Given this list of marker genes CES2, DOCK2, CRTAP, TNS3, BCL3, TOM1, SLC3A2, C1orf162, SLC25A28, BTBD2, RIPOR1, CD33, LILRA6, NCLN, ARRDC3, ENTREP3, NACC2, GRN, CARM1, BHLHE40, CXCL16, HLA-DRB4, CSF1R, ACSS2, ZNF362, GRAMD4, SPG21, CREG1, ADAP1, JMJD8, SLC26A6, ALOX5, SRF, NINJ1, GMEB2, MILR1, CIRBP (NCBI Gene Id 1153), ZNF467, ADAP2, ALDH1A1, GAS7, PFKFB3, VSIR, CD86, IMPDH1, OAF, CNPY3 (canopy FGF signaling regulator 3), PPM1F, ANXA5, RCC2, NAPRT, C9orf72, H3-3B, GADD45B, PNPLA6, LILRA3, MAPKAPK3, RNASET2, PIM3, TYK2, CDC37, ZNF296, FUT4, MPEG1, CTNNA1, CENPB, ZDHHC7, RAPGEF1, ZNF598, SLC66A2, TNFRSF1B, CLCN7, KATNIP, TBC1D2 (NCBI Gene Id 55357), FAM156A, RFNG, LGALS9, ALDOA, ULK1, FAAP100, WWP2, DAZAP2, AP1S2, CMIP, LRP3, MACROH2A1, RHOG, SEPTIN9, HCFC1, TPD52L2 (NCBI Gene Id 7165), KDM2B, SLC9A1, DMXL2, SNX27, ADAM15, CALM3, SLC43A2, NSMF, KHSRP, C15orf39, MYOF, CHST13, ZYX, ALDH2, RAB40C, ATF5, ALAD, CDC42EP3, PLSCR1 (phospholipid scramblase 1), BCKDK, FBP1, HNRNPH2, ATP6AP1, GNAQ, TRIM8, IRF1, TGOLN2, CCNY, STK25, KLF10, KLF11, ATP6V0A1, PSAP, BICRA, CD300C, TSPO, H3-5, ZMIZ1, NIBAN2, ITGB2, PIEZO1, SHFL, NUAK2, MAP3K20, JARID2 (NCBI Gene Id 3720), SLC2A6, MYH9, RUNX3, RNPEP, ABR, CBX4, RAB44, FGR, DENND5A, NCSTN, CLEC16A, LZTR1, CUEDC1, here is a description of the gene set: species: Homo sapiens Human Gene Set: THAKAR_PBMC_INACTIVATED_INFLUENZA_AGE_70PLS_NONRESPONDER_2DY_DN To elucidate gene expression pathways underlying age-associated impairment in influenza vaccine response, we screened young (age 21-30) and older (age >= 65) adults receiving influenza vaccine in two consecutive seasons and identified those with strong or absent response to vaccine, including a subset of older adults meeting criteria for frailty. PBMCs obtained prior to vaccination (Day 0) and at day 2 or 4, day 7 and day 28 post-vaccine were subjected to gene expression microarray analysis. We defined a response signature and also detected induction of a type I interferon response at day 2 and a plasma cell signature at day 7 post-vaccine in young responders. The response signature was dysregulated in older adults, with the plasma cell signature induced at day 2, and was never induced in frail subjects (who were all non-responders). We also identified a mitochondrial signature in young vaccine responders containing genes mediating mitochondrial biogenesis and oxidative phosphorylation that was consistent in two different vaccine seasons and verified by analyses of mitochondrial content and protein expression. These results represent the first genome-wide transcriptional profiling analysis of age-associated dynamics following influenza vaccination, and implicate changes in mitochondrial biogenesis and function as a critical factor in human vaccine responsiveness. Genes down-regulated in peripheral blood mononuclear cell 2d vs 0d in seniors (70+) (nonresponder) after exposure to Inactivated influenza vaccine, time point 2D from publication Thakar J, Mohanty S, West AP, Joshi SR, Ueda I, Wilson J, Meng H, Blevins TP, Tsang S, Trentalange M, Siconolfi B, Park K, Gill TM, Belshe RB, Kaech SM, Shadel GS, Kleinstein SH, Shaw AC (PMID 25596819)